The following is a description of a gene set: studied in species Homo sapiens A developmental process, independent of morphogenetic (shape) change, that is required for an anatomical structure, cell or cellular component to attain its fully functional state. Human Gene Set: GOBP_DEVELOPMENTAL_MATURATION, and this is the list of marker genes: STXBP1, BCL2, ATP6V1G1 (NCBI Gene Id 9550), RAB32, GLDN, C1QL2, NPPC, NPR2, CCDC154, TRPC4AP, IGF1 (NCBI Gene Id 3479), FGFR1, BAIAP3, SOX18, ANKRD27, ACTL6B, WNT10B, KDR, WNT1, SPTBN4, C1QA (complement C1q A chain), C3, CHRDL1, GHRHR (growth hormone releasing hormone receptor), BLOC1S6, BHLHA15, TDRKH, ATP6V1G3, CD63 (CD63 molecule), RAC1, TMEM79, FGFR3, FEM1B, SPINK5, LYL1, LTF, ATP6V1F, ATP6V1B2, BMP2, ZBTB7A, IQCF1, RAB3A, GBA1, CCNB1, PGR, APP, ADAMTS12, EFCAB9, WEE2, TBX6, NGF, AP1M1, HDAC6, TDRD1, ROPN1, PDE3A, MECP2, SNX19, C1QL1, FBXO5, PTBP3, RFLNB, AXL, ATP6V1G2, EREG, FGF7, EPB42, DEFB1, CDKN1C, ADAMTS7, PAEP, RAB38, RHEX, C2CD6, TRIP13, SPG21, NFATC4, ACTN3, ELSPBP1 (NCBI Gene Id 64100), ERCC2, RFX3, SCARF1, MOS, CCL21 (NCBI Gene Id 6366), SYP, SRRM4, DLGAP4 (DLG associated protein 4), H3-3B, DAZL, NOM1, CABYR, LHX6, CCR6, SEMG1, EDNRA, REC8, GALNT3, LEP, FBXO41, LGI4, ATP6AP1, FAM210B, EXT1, ZDHHC15, WDR77, CDH3, TGFB1, PICK1 (protein interacting with PRKCA 1), HOXB13, ZDHHC20, BAP1 (NCBI Gene Id 8314), AGRN, PRKACA, RND1, NEURL1, LNX1 (ligand of numb-protein X 1), SOX8, CX3CR1, TMIGD1, XBP1, RBPJ, HID1, ATP6V0A1, ADAM7, PCSK4, NFIA, SOX10, CDC20, CLCN3, SLFN14, MYOC, NRN1, SNX10, CCDC39, GPAT4, KLF2, DLD, IFT80, ROPN1L, RELN, LCN6, DIAPH3 (diaphanous related formin 3), YWHAZ, DDIT3, PFN1, BLOC1S5, NTN4, IGSF9, WASHC5, G6PD, NEUROD2, TMPRSS12, EPAS1, SIX3, KDM1A, PTH, SCLT1, TCP11X2, TDRD5, ARCN1, H3-3A, NRXN1, TCP11X1, SMIM45, TFCP2L1 (transcription factor CP2 like 1), EDN1, ANAPC2, FLVCR1, ZAR1L, PPP2R1A, ATP6V1B1, TDRD6, CCL19, EPHA8, SHB, P2RX5, HEATR3, XYLT1, KCNE1 (NCBI Gene Id 3753), GATA2, BSPH1 (NCBI Gene Id 100131137), RXFP2, TDRD7, BNC1, SHANK1, BCL11A, FARP2, CNTNAP2, CAMK2B, PLXNB1, BLOC1S3, RERE, ARHGEF15, RAC2, MBTPS2, NKX6-1, IER3IP1, ATP6V1E1, ZBTB16, KCNB1, CDK5R2, CATSPERE, L3MBTL3, IRX5 (NCBI Gene Id 10265), FERMT1, SLC22A14, ZAR1, TRIM58, GDF11, VEGFA, ZDHHC2 (NCBI Gene Id 51201), ATP6V1C1, SLC24A4, RAC3, CLN5, BFSP2, CNGB1, TUT4, WNT5A, IGSF21, RYR1, BTK, PTH1R, ANKS1A, DAB2IP, ROPN1B, HBZ, SNX27, SNAPIN, DAG1, VPS35, CATSPER3, SLC26A6, AGO2, ASCL1, RAB24, SIRT2, CLEC7A, PTEN, GH1, RET, FOXJ1, ADGRB3, ACVRL1 (activin A receptor like type 1), S1PR1, MAP3K13, RPS6KA2, CDH5, OOSP2, GAL, ATP6V0C, CBFB, NR4A2, SPINK1, TGFB2, ATP6V1A, GATA3, DMC1, CLSTN1, DISC1, CDK5R1, SLC26A3 (solute carrier family 26 member 3), EPO, PTPRN, PAX2, ATP6AP2, DLG4, EDNRB, RFLNA, PLD6, TUSC2, DAB1, FAM20C, CATSPERD, SEMA4D, PLA2G3, CATSPER2, VSX1, TCP11, TAL1, MAP1B, SEZ6, ATP6V0D1, DCHS1, REN, B4GALT6, HES5, RB1, LSM14B, B4GALT5 (beta-1,4-galactosyltransferase 5), FEV, RHOA, ALDH1A2, TUBB8, FOXA1, BFSP1, CEBPA, BRCA2, ID2, MAEA, TUT7 (NCBI Gene Id 79670), SEMA7A, KCNIP2, THBS3, CDC25B, CATSPER4, RUNX2 (NCBI Gene Id 860), AP1G1, NEMP1 (NCBI Gene Id 23306), NSUN2, NRCAM, CNTNAP1, ABHD2, SEZ6L, SEZ6L2, YTHDF2, SEMG2, SYBU, RECK, ATP6V1D, FGF22, PICALM, ANGPTL8, MSX2, PPARG, CFTR, IHH, PHOSPHO1, LRRK2, EBP, CTNNB1, HES1, AURKA, PLA2G10, FOXO3, CX3CL1, NF1, ANG, MMP2, IL15, IL21, MTCH1, NEFL, ROCK1, AKR1B1, HOXA5, CNTN2, HIF1A, PALM, CEND1 (cell cycle exit and neuronal differentiation 1), BCAN, KCNQ3, CATSPERZ, FUT6, AP3D1 (NCBI Gene Id 8943), KIF14, BRD1, FZD5, SLC17A7, GREM1, ATP6V0A4